The following is a description of a gene set: part of: Deadenylation-dependent mRNA decay Reactome Pathway: mRNA decay by 5' to 3' exoribonuclease Degradation of mRNA from 5' to 3' occurs in three steps. First, the mRNA is bound at its 3' end by the Lsm1-7 complex. The bound Lsm1-7 may prevent nucleases from accessing the 3' end. Second, the 7-methylguanosine cap of the mRNA is hydrolyzed by the DCP1-DCP2 complex. Third, the 5' end of the decapped mRNA is attacked by the XRN1 exoribonuclease which digests the remainder of the mRNA from 5' to 3'. These processes may be physically connected by PATL1, the homolog of yeast Pat1, which stably binds the Lsm1-7 complex and interacts with the DCP1-DCP2 decapping complex and the Ccr4-NOT deadenylation complex. species: Homo sapiens, and this is the list of marker genes: LSM2, DDX6, DCP1B, EDC3, LSM3, LSM7, XRN1, LSM1, DCP1A, LSM4, LSM5, LSM6, DCP2, PATL1, EDC4